Given this list of marker genes CDK1, SPC25, CPA3, TOP2A, CSTA, MPO, RNASE2CP, HGF, MS4A3, CLC, NDC80 (NCBI Gene Id 10403), RNASE2, here is a description of the gene set: from publication Graham SM, Vass JK, Holyoake TL, Graham GJ (PMID 17717066) Human Gene Set: GRAHAM_CML_QUIESCENT_VS_CML_DIVIDING_DN Genes down-regulated in quiescent (G0) vs dividing (M) CD34+ cells isolated from peripheral blood of CML (chronic myeloid leukemia) patients. species: Homo sapiens Quiescent and dividing hemopoietic stem cells (HSC) display marked differences in their ability to move between the peripheral circulation and the bone marrow. Specifically, long-term engraftment potential predominantly resides in the quiescent HSC subfraction, and G-CSF mobilization results in the preferential accumulation of quiescent HSC in the periphery. In contrast, stem cells from chronic myeloid leukemia (CML) patients display a constitutive presence in the circulation. To understand the molecular basis for this, we have used microarray technology to analyze the transcriptional differences between dividing and quiescent, normal, and CML-derived CD34+ cells. Our data show a remarkable transcriptional similarity between normal and CML dividing cells, suggesting that the effects of BCR-ABL on the CD34+ cell transcriptome are more limited than previously thought. In addition, we show that quiescent CML cells are more similar to their dividing counterparts than quiescent normal cells are to theirs. We also show these transcriptional differences to be reflected in the altered proliferative activity of normal and CML CD34+ cells. Of the most interest is that the major class of genes that is more abundant in the quiescent cells compared with the dividing cells encodes members of the chemokine family. We propose a role for chemokines expressed by quiescent HSC in the orchestration of CD34+ cell mobilization. Disclosure of potential conflicts of interest is found at the end of this article.